The following is a description of a gene set: Any process that decreases the rate, frequency, or extent of the growth of a cardiac muscle cell, where growth contributes to the progression of the cell over time from its initial formation to its mature state. Human Gene Set: GOBP_NEGATIVE_REGULATION_OF_CELL_GROWTH_INVOLVED_IN_CARDIAC_MUSCLE_CELL_DEVELOPMENT species: Homo sapiens, and this is the list of marker genes: G6PD, MIR199A1, GSK3A, MIR199B (microRNA 199b), TOMM70, CTDP1, PPARA, CAV3, RGS4, RGS2, PAK1, FOXP1, YY1, PI16